The following is a description of a gene set: Mouse Gene Set: GOBP_DENTINOGENESIS species: Mus musculus The process whose specific outcome is the formation of dentin, the mineralized tissue that constitutes the major bulk of teeth. Dentin may be one of three types: primary dentin, secondary dentin, and tertiary dentin., and this is the list of marker genes: Dspp, Serpine1, Tcirg1, Smpd3, Fam20c